The following is a description of a gene set: Mouse Gene Set: GOCC_PROTEASOME_ACCESSORY_COMPLEX studied in species Mus musculus A protein complex, that caps one or both ends of the proteasome core complex and regulates entry into, or exit from, the proteasome core complex., and this is the list of marker genes: Psmd5 (proteasome (prosome, macropain) 26S subunit, non-ATPase, 5), Psmd4, Psmd1, Psmc3, Adrm1, Psmd12, Psmd13, Psmc2, Psme1, Psmd9, Adrm1b, Psmd6, Psme3, Psmd7, Psmd8, Psmc5, Psmd14, Sem1, Psmc1, Psmc4, Psme2, Psmc6, Psmd3, Psmd10, Psmd11, Psmd2